Given this list of marker genes GJB6 (gap junction protein beta 6), UROS, AIRE, TRAPPC11, TARS1, AARS1, GJB2, HLA-B, FBN1, ERCC2, IARS2, CCR1, CARS1, COL17A1, ERCC8, MTTP, RNF125, GSN, BTNL2, ATP2A2, KLRC4, TP63, RECQL, GTF2H5, PAX6, NLRP1, AAAS, FGFR3 (NCBI Gene Id 55546), IFNGR1, LYZ, FAS, MEFV (MEFV innate immunity regulator, pyrin), IL12A-AS1, ZFX, GTF2E2, ERCC6, IL12A, ERAP1, MAB21L1, FGF10, IL23R, GATA1, AEBP1, STAT4, SREBF1, FOXC1, HLA-DRB1, LBR, ERCC3, SCN9A, HLCS, C4A, FGFR2, IL10, NOD2, GMPPA, TLR4, TRIM44, UROD, RNF113A, MPLKIP, UBAC2, here is a description of the gene set: Human Gene Set: HP_KERATOCONJUNCTIVITIS species: Homo sapiens Inflammation of the cornea and conjunctiva. Keratoconjunctivitis